Given this list of marker genes SHISA7, EPHB2, RAPSN, LHFPL4, MESD, SHISA6, NLGN3, NRXN1, CRKL, DLG4, FNTA, CHRDL1, RER1, NLGN1, DVL1, APOE, MUSK, LRP4, GLRB, GPHN, NRXN2, ETV5, NLGN2, DNAJA3, CRK, CRIPT (CXXC repeat containing interactor of PDZ3 domain), CDH2, GDNF, COLQ, CHRNB1, DOK7, SLC7A11, LRRC4, ZMYND8, FRRS1L, RAC1, SSH1, SLC30A1 (NCBI Gene Id 7779), FZD9, ZDHHC2, SHANK3, RELN, FARP1, here is a description of the gene set: Human Gene Set: GOBP_POSTSYNAPTIC_MEMBRANE_ORGANIZATION A process which results in the assembly, arrangement of constituent parts, or disassembly of a postsynaptic membrane, the specialized area of membrane facing the presynaptic membrane on the tip of the nerve ending and separated from it by a minute cleft (the synaptic cleft). species: Homo sapiens